The following is a description of a gene set: from publication Cao J, O'Day DR, Pliner HA, Kingsley PD, Deng M, Daza RM, Zager MA, Aldinger KA, Blecher-Gonen R, Zhang F, Spielmann M, Palis J, Doherty D, Steemers FJ, Glass IA, Trapnell C, Shendure J (PMID 33184181) Marker genes curated from the annotated cluster as represented in the Descartes Human Gene Expression During Development database. species: Homo sapiens Human Gene Set: DESCARTES_MAIN_FETAL_ENS_NEURONS The gene expression program underlying the specification of human cell types is of fundamental interest. The study authors generated human cell atlases of gene expression and chromatin accessibility in fetal tissues. For gene expression, the study authors applied three-level combinatorial indexing to >110 samples representing 15 organs, ultimately profiling ~4 million single cells. The study authors leveraged the literature and other atlases to identify and annotate hundreds of cell types and subtypes, both within and across tissues. Our analyses focused on organ-specific specializations of broadly distributed cell types (such as blood, endothelial, and epithelial), sites of fetal erythropoiesis (which notably included the adrenal gland), and integration with mouse developmental atlases (such as conserved specification of blood cells). These data represent a rich resource for the exploration of in vivo human gene expression in diverse tissues and cell types., and this is the list of marker genes: HTR4 (5-hydroxytryptamine receptor 4), RGSL1, TNS3 (tensin 3), DLG2-AS2, ENSG00000226454, IQCJ, JAKMIP1-DT, HMX2, OPRD1 (NCBI Gene Id 4985), NOS1 (nitric oxide synthase 1), LINC02641, HEATR5A, TLX2, LIX1, HOXB5, EML5, NRG2, HMGN1P14, PCDHA13, VIP, GPC6-AS2, HOXB4, RPL10P13, SMIM28, HTR3B, LTK, DPYSL3, FGF13, GPR176, PHOX2B-AS1, CELF3, DTD1-AS1, ETV1, GRK3, ZNF843, NAMA, TNPO1, CNGB1, PPEF1, GARNL3, NRSN1, MYH15